Given this list of marker genes EHD4, ETFB (electron transfer flavoprotein subunit beta), WDR83, RNF186, RN7SKP134, PRCC, KRIT1, UBE2N, TNFSF9, FAM222B, TLCD1, PLA2G4E-AS1, HSPA4, HAX1, MRPL27, ZNF580, NDUFAF4P1, ZNF384, PPOX, PPP1R13L, TPI1P2, ZNF581, ERAL1, HDGF, PFDN1, POLR1G, GALK2 (galactokinase 2), SNORA3A, CHCHD5, BCAS2, KATNB1, ZWILCH, ERCC1, SNAPC5, NEK8, KBTBD2, ANKIB1, EMC4, COPS2, TNPO3, PSMA5, C2orf49-DT (NCBI Gene Id 100508612), SCAMP5, CFL1, RNU7-27P, C2orf49, RPL4, ZNF358, PLBD1, RPL27A (ribosomal protein L27a), ZNF484, TMEM209, CCDC28A-AS1, EME1, CEP44, CSDE1, WDR83OS, CNOT4, USE1, TSPAN31, HINT2, ZNF441, PRPF31, IFRD1, TSEN2, CCDC28A, EEF1G, RNASEL, TEAD4, HCG15, TFPT, MUS81, here is a description of the gene set: Human Gene Set: RAX2_TARGET_GENES studied in species Homo sapiens Genes containing one or more binding sites for (RAX2) in their promoter regions (TSS -1000,+100 bp) as identified by GTRD version 20.06 ChIP-seq harmonization. from publication Yevshin I, Sharipov R, Kolmykov S, Kondrakhin Y, Kolpakov F (PMID 30445619)